Given this list of marker genes SMG9, TGDS, ALG9, TEFM, TSPEAR, RHOBTB2, MADD, here is a description of the gene set: Human Gene Set: HP_LOW_INSERTION_OF_COLUMELLA Insertion of the posterior columella below the nasal base. Low insertion of columella studied in species Homo sapiens